The following is a description of a gene set: Genes negatively differentially expressed in cell type: B cell upon treatment with cytokine: IFN-α1 in mouse lymph nodes in vivo. Cytokines mediate cell-cell communication in the immune system and represent important therapeutic targets. A myriad of studies have highlighted their central role in immune function, yet we lack a global view of the cellular responses of each immune cell type to each cytokine. To address this gap, the authors created the Immune Dictionary, a compendium of single-cell transcriptomic profiles of more than 17 immune cell types in response to each of 86 cytokines (>1,400 cytokine-cell type combinations) in mouse lymph nodes in vivo. A cytokine-centric view of the dictionary revealed that most cytokines induce highly cell-type-specific responses. For example, the inflammatory cytokine interleukin-1β induces distinct gene programmes in almost every cell type. A cell-type-centric view of the dictionary identified more than 66 cytokine-driven cellular polarization states across immune cell types, including previously uncharacterized states such as an interleukin-18-induced polyfunctional natural killer cell state. from publication Cui A, Huang T, Li S, Ma A, Pérez JL, Sander C, Keskin DB, Wu CJ, Fraenkel E, Hacohen N (PMID 38057668) species: Mus musculus Mouse Gene Set: CUI_B_CELL_IFNA1_RESPONSE_DN, and this is the list of marker genes: Rgs2 (NCBI Gene Id 19735), Uqcrh, Chd3, Ogt, Smim14, Pold4 (NCBI Gene Id 69745), Neurl3, Pglyrp1, Rasgrp2, Ikzf3, Btg1, Sfpq, Trim7, Ctsh, Ralgps2, Slc12a6, Dennd5b, Nrm, Atp2a3, Marchf1, H3f3a, Gnai2, Ier5, St8sia4, Hvcn1, Sec11c, Fau (FAU ubiquitin like and ribosomal protein S30 fusion), Limd2 (NCBI Gene Id 67803), Lbh, Pcmtd1, Kif21b, Cd84, Pbxip1, Gabarap, Akap13, Jakmip1, Top2b, Gimap3, Coro1a, Snx29, Tspan13, Calm3, Tcp11l2, Cxcr4, Foxp1, Myl6, H2-Ob, Cyba, Cd37, H1f4, Crip1, Cd79a, Snapc5, Gpx1, Gmfg, Ptprc, Cmah, Lcp1, Cotl1, Vpreb3, Macf1, Ftl1, Pfdn5, Cd79b, Higd2a, Gm2a, Tbc1d10c, Calm1, Bank1, Retreg1, Ccr7, Zfp36, Septin6, Tln1, Cyp4f18 (NCBI Gene Id 72054), S100a10, Sting1, Chchd10, H2-DMb2, Dnase2a (NCBI Gene Id 13423), Klf6, Atox1, Foxn3, Supt20, Myh9, Cd200, Fcer2a, Fam107b, H2-Ab1, Iglc3, Kctd12, Klhl24, Cnn2, Ptpn18, Trim5, Map3k1, Klf2, Pgap1, Acp5, Tubb5, H2-DMa, AB124611, Fos, Jmjd1c, Tmem108, Tnfrsf13b, Gsn, Add3, Junb, Ripor2, Dmxl1, Mxd4, Man1a, Pax5, H2az2, Arhgdib, Reep5, H2-Eb1, Tsc22d3, Mef2c, Txnip, Parp1, Ddx17, Zfp950, Fmnl1, Stk17b, Kdm7a, Cst3 (NCBI Gene Id 13010), Sh3kbp1, Grk6, Lamtor2, Gpx4 (glutathione peroxidase 4), Rac2, Tle5, Oaz1, Wasf2, Chst3, Ebf1, Rhob, Sesn3, Slc38a1, Ypel3, Sh3bgrl3, Lsp1, Apoe, Pou2f2, Uba52 (ubiquitin A-52 residue ribosomal protein fusion product 1), Aff4, Fth1, Stap1, Fcrla, Emp3, Arhgap45, H2-Aa, Cd55, Pxdc1, Prkcb (protein kinase C, beta), Ets1, Sgms1, Cr2, Sorl1, Ddx5, Iglc2, Flna, Arid5b, H2-Oa, Siglecg, Tspan32, Cd22, Hhex, Lars2, Rabac1, Cdk2ap2, Cd81, Lrrk2, Malt1, H1f2, Diaph1, Ighm, Prcp, S100a11, Fcgr2b, Myl12b, Rnf130 (NCBI Gene Id 80609), Hexb, Rabgap1l, Cox7a2l, Rasa3, Gpsm3, Cd52, Rnaseh2c